Given this list of marker genes PLCH2, DLEC1, FADS1, ABCG1, ADAM28, AIMP1, IMPA2, NACA, TCAF1, EPRS1, EFNB3, TNFSF14, ADAMDEC1, MTSS1, NADK, PUM2, SERTAD2, VEGFA, SPHK2, POLR2H, DCHS1, ENTPD6, ARHGAP5, PIP4K2B, UTP18, CHIT1, HMGB2, RRAGA, IRAK3, STX6, FOS, NME4, PANK3, MXRA7, LY86, PTOV1, ECE1, HIVEP1, CD151, GNRH2, RNASEH2B, RNASE4, MUC6, ME1, SDC3, SNUPN, CTDSP2, RPS4Y1, KIAA0930, FBL, RPA3, VCAN, BABAM2, GPNMB (NCBI Gene Id 10457), RECQL5, RNF44, PSMA7, POLR2I, TPP1, CSTA, VGLL4, GTF3A, RPS6KA2, ADNP, TUSC2, ZFP36L1, PEPD, HTR1B, MIOS, HOMER3, IFT20, DTNB, MMP7, SYPL1, MPC2 (NCBI Gene Id 25874), USP34, INHBC, FYN, ZFYVE26 (zinc finger FYVE-type containing 26), MMP1, ARF5, ENO2, CALM3, TBP, PGM1, ADD3, STOML2, RAB4A, DLG2, TSNAX, CDC5L, PCSK6, RPS4X, COL2A1, CIR1, CHST15, SORL1, USF2, PHC2, AMHR2, SNTB2, DCP2, RALA, TBL1X, FAM53B, REPS1, ACVR1, PC, WDR43, OLFML2B, KTN1, SAP30, YARS1, REG1A, GAS2L1, SEMA4D, IDS, RNF187, NOLC1, IQSEC2, AKR7A2, NDRG1, PRRC2B, MLF2, ARL4C, PRDX2, PTPRCAP, NBAS, FOXO3, CXCL2, ADH6, LMNA, SELENOW, FDPS, ALDH9A1, CD33, ARR3, IGHG1, SCG5, IFT25, RAB32, TSPAN4, CD163, CNOT3, RPS27A, BCL2A1 (NCBI Gene Id 597), HMGN1, ATP5MJ, ACAT2, CRTAP, SPIDR, PADI2, LTA4H, IL10RB, CRABP2 (cellular retinoic acid binding protein 2), SSBP1, PEMT, SORD, UPF3A, AIF1, SNAPC2, SPINK4, PHF3, UBXN2B, FCER1G, DGAT1, GALC (galactosylceramidase), SART3, PLOD2, NUPR1, BTAF1, ADA, ZMYND8, EEF1G, MSR1, ALDH2, THAP3, LGMN, CDH13, SEPTIN9, ALOX5, HEBP2, SPARC, IL2RG, COL4A3, LMO4, SMPDL3A, CD300A, RPL21, VSIG4, FRAT2, PTEN, RUVBL2, TFE3, CXCL3, CLK1, CETN2, PPP2R5D, LILRA2, JRKL, here is a description of the gene set: from publication Chaussabel D, Semnani RT, McDowell MA, Sacks D, Sher A, Nutman TB (PMID 12663451) Human Gene Set: GSE360_DC_VS_MAC_M_TUBERCULOSIS_DN Monocyte-derived dendritic cells (DC) and macrophages (MΦ) generated in vitro from the same individual blood donors were exposed to five different pathogens, and gene expression profiles were assessed by microarray analysis. Responses to Mycobacterium tuberculosis and to phylogenetically distinct protozoan (Leishmania major, L. donovani, Toxoplasma gondii) and helminth (Brugia malayi) parasites were examined, each of which produces chronic infections in humans yet vary considerably in the nature of the immune responses they trigger. Genes down-regulated in comparison of dendritic cells (DC) exposed to M. tuberculosis versus macrophages exposed to L. major. species: Homo sapiens